The following is a description of a gene set: Any process that modulates the frequency, rate or extent of macrophage differentiation. Human Gene Set: GOBP_REGULATION_OF_MACROPHAGE_DIFFERENTIATION studied in species Homo sapiens, and this is the list of marker genes: CASP8, CALCA, GATA2, MIR486-1, HCLS1, TAOK3, ADIPOQ, HSF1, PTPN2, ID2, QKI, C1QC, TRIB1, MIR145, INHA, IL34, PRKCA, RIPK1 (NCBI Gene Id 8737), TGFB1, MIR223, PF4, RB1, CSF1, INHBA, ZBTB46, FADD, LIF